Given this list of marker genes NFE2L2, ME1, IDH1, here is a description of the gene set: studied in species Homo sapiens Sub-pathway representing TCA cycle genes regulated by NFE2L2. NFE2L2 has a role in directing cellular metabolic processes in normal and cancer cells. By regulating the TCA-specific genes, it controls the progression of the TCA cycle in stress and disease conditions Reactome Pathway: NFE2L2 regulating TCA cycle genes part of: Nuclear events mediated by NFE2L2